Given this list of marker genes Lgals9, Btk, Ccr5, Lbp, Pou2af1, Defb25, Fcer1g, Il1b, Hmgb1, Tlr4, Ager, Crhr2, Mapk13, Cd74, Il1rl2, Bsg, Ereg, Dhx9, Setd4, Ifih1, F2r, Grk2, Card9, App, Ccn1, Ticam1, C1qtnf4, Traf6, Aif1, Ptafr, Selenok, Tbc1d23, Tlr9, Lep, Pten, Tlr6, Hspd1, Trpv4, Akirin2, Nos2, Stat3, Lilra5, Il33, Il36b (NCBI Gene Id 69677), Wnt5a, Tlr8, Twist1, Ifng, Rigi, Tmem106a (transmembrane protein 106A), Tut4, Adora2b, Tlr7, Myd88, Pou2f2, Unc93b1, Arhgef2, Inava, Cyba, Ripk2 (receptor (TNFRSF)-interacting serine-threonine kinase 2), Il17ra, Tnf, Sphk2, Cd36, Tlr2, Rela, Tlr3, Adcyap1, Ucn, Tnfsf4, Hyal2 (NCBI Gene Id 15587), Lpl, Zbtb20, Tlr1, Vegfd, Il16, Xbp1, Clec7a, Scimp, Il6, F2rl1, Ncl, Isl1, Il36a, Nlrp10, Tirap, Nod1, Tslp, Il17f, Mavs, P2rx7, Laptm5, Il17a, Il1rap (interleukin 1 receptor accessory protein), Il17rc, Il1a (interleukin 1 alpha), Mbp, Arid5a (NCBI Gene Id 214855), Syk, Pycard, Tnfsf9, Il6ra, Il17d, Nod2, Plcg2, Spon2, Tyrobp, Il36g, Ticam2, Rab7b, Tgfb1, here is a description of the gene set: Mouse Gene Set: GOBP_POSITIVE_REGULATION_OF_INTERLEUKIN_6_PRODUCTION studied in species Mus musculus Any process that activates or increases the frequency, rate, or extent of interleukin-6 production.